The following is a description of a gene set: from publication El Kasmi KC, Holst J, Coffre M, Mielke L, de Pauw A, Lhocine N, Smith AM, Rutschman R, Kaushal D, Shen Y, Suda T, Donnelly RP, Myers MG Jr, Alexander W, Vignali DA, Watowich SS, Ernst M, Hilton DJ, Murray PJ (PMID 17114459) IL-10 or IL-6 stimulation of control 129xC57BL/6 murine bone marrow derived macrophages in the presence of LPS. We used microarrays to detail the global programme of gene expression changes in response to IL-6 or IL-10 stimulation in the presence of lipopolysaccharide. BMDMs were isolated from control, IL-6-/-, and IL-10-/- mice on a 129XBL/6 mixed background mice and differentiated in the presence of CSF-1 for 6-7 days. Cells were scraped and plated in 6 well plates at 2x10e6/well. Cells were washed with complete DMEM and rested for 1-2 hr before stimulation with combinations of IL-10 (10 ng/ml), IL-6 (2 ng/ml) or LPS (100 ng/ml) for 45 min or 180 mins. Complete biological replicates were performed. Genes up-regulated in bone marrow-derived macrophages with IL10 knockout and 45 min of stimulation by: LPS versus LPS and IL10. species: Homo sapiens Human Gene Set: GSE5589_LPS_VS_LPS_AND_IL10_STIM_IL10_KO_MACROPHAGE_45MIN_UP, and this is the list of marker genes: MAP1LC3B, RNASE4, GATD3, RETREG1, MEGF8, RAB2B, CAMTA1, NUP62, ATXN7L3B, ST6GAL1, SNX3, FNIP2, NUAK1, RNF103, GNB5, ZFHX3, TMEM106C, PIGS, MPV17, SMAGP, SETD7, WWP1, ITGB5, EEA1, TBC1D14, PER3, EXOC3 (NCBI Gene Id 11336), YIPF2, DOCK4, CITED2 (Cbp/p300 interacting transactivator with Glu/Asp rich carboxy-terminal domain 2), MORF4L1, HPGD, FXR1, SEPTIN8 (NCBI Gene Id 23176), ELMOD2, SPG11, TMEM50A, TARS3, NCKIPSD, ANKRD46, IRAK1BP1, DDX3X, P2RY12, ZNF449, CHST14, NECAP2, SPECC1L, PIAS3, ID3, KIFBP, C6orf120, CHD9, PRRG1, LRP1, SLC35F5, LIMA1, DCTN1, GCC2, SEMA6D, CBX2, CYB5A, ATRAID, RDH10, LMAN2, CAMSAP2, ETV1, USP9X, ATP6V0D1, HFE, PGGT1B, GGA2, CNOT8, SLC9A9, ZNF277, PLSCR3, PTOV1 (PTOV1 extended AT-hook containing adaptor protein), GYG1, RNF180, SOCS6, ATRX, DHX57, PPM1H, H2BC13 (NCBI Gene Id 8340), DPY19L4, MFSD1, TMEM256, AP3M2, ZNF629, RAPSN, SNX9, SIRT2, EPC2, NR1D2, FBXL4, ZFYVE21, WDFY3 (WD repeat and FYVE domain containing 3), NUDT16L1, TPD52L2, ING4 (NCBI Gene Id 51147), ATP2B1, PLPP6, KIDINS220, PLSCR4, SERTAD4BP, TSPAN17, CSAD, ZNF260 (NCBI Gene Id 339324), PIK3R4, PHF13, MPHOSPH8, CTTNBP2NL, DENND5A, STX1A, SULF2, TMEM141, SEL1L, ARFGEF3, LDAF1, LAPTM4B, BTBD7, TSPAN4, BMPR2, VAMP3, PRKRA (NCBI Gene Id 94716), ATXN1, CAMK1, PIGP, LAPTM4A, TSPAN31, TMEM106B, CYB5R1, ABL1, RAB11FIP5, BCAS3, RIN2, DIP2A, YPEL2, SENP8, MNT, ANKRD28, GPR146, PRKAB2, OPA1, LRSAM1, TREM2, GLMP, FAHD1, RNASEL, HECTD3, ALKBH3, TTC8, CNOT4, HLX (NCBI Gene Id 3142), ABHD14B, PDZD8, ADRB2, TOX2, KCNK13, SNAPIN, GOLGA4, MTURN, GGACT, NHSL3, FUNDC1, MBLAC2, LDLRAD3, ARHGEF12, ZBTB11-AS1, RERE, JADE1, ARHGAP12, MPG, PMP22, MED7, OPHN1, POGLUT3, PKD1, CAST, RNF145, ADAM21, SLC12A6, SKI, TRIM44, TCP11L2, CCDC90B, PTPRA, POT1, PIR, MCFD2, IRGQ, TMEM9B, MON2, YIPF4, REPIN1, SPIRE1, GPAM, SEC14L1, TMEM132A, ZSCAN12, CD99